The following is a description of a gene set: Mouse Gene Set: chr6D2 species: Mus musculus, and this is the list of marker genes: Gm17822, Mir7041, Gm7833, Lrig1, Gm5723, Suclg2, Slc25a26, 4930511E03Rik, AY512915, Kbtbd8os, Kbtbd8